Given this list of marker genes Acvr2a, Bmpr1a, Ly6g6e, Hjv, Acvr2b, Tgfbr2, Tgfbr3l, Amhr2, Acvr1b, Acvrl1, Acvr1c, Sostdc1, Tgfbr1, Bmpr1b, Acvr1, Bmpr2 (bone morphogenetic protein receptor type 2), Tgfbr3, here is a description of the gene set: studied in species Mus musculus Combining with a signal and transmitting the signal from one side of the membrane to the other to initiate a change in cell activity by catalysis of the reaction: ATP protein serine = ADP + protein serine phosphate, and ATP + protein threonine = ADP + protein threonine phosphate. Mouse Gene Set: GOMF_TRANSMEMBRANE_RECEPTOR_PROTEIN_SERINE_THREONINE_KINASE_ACTIVITY